The following is a description of a gene set: Extended zone of intimate apposition between two cells containing one or more types of intercellular junctions, e.g., the intercalated disk of muscle. Mouse Gene Set: GOCC_CELL_CELL_CONTACT_ZONE studied in species Mus musculus, and this is the list of marker genes: Cxadr, Slc8a1, Ctnna3, Jam3, Nectin3, Nectin2, Cav3, Vamp5, Ankrd23, Slc9a1, Actn1, Rap2b (RAP2B, member of RAS oncogene family), Pecam1, Pcdh9, Gm1123, Tln2 (talin 2), Cdh2, Pik3ca, Gja5, Ptk2, Dsp, Kcnj11, Pcdha9, Scn5a, Slc31a1, Nrap, Atp1a2, Vcl, Scn1b, Tiam1, Baiap2l2, Prkca, Tjp2, Ank2, Sptan1, Slc2a1, Dsc2, Pkp2, Des, Anxa6, Rangrf, Fxyd1 (FXYD domain-containing ion transport regulator 1), Kcnj2, Sptbn4, Atp1b1, Bloc1s6, Kcna5, Gja1, Scn2a, Afdn, Ywhah, Fgfrl1, Ctnnb1 (catenin beta 1), Gja6, Ajap1, Hamp, Scn1a (sodium channel, voltage-gated, type I, alpha), Slc4a1, Adra1b, Flcn, Ank3, Pgm5, Ahnak, Anxa5, Dsg2, Jup, Ctnna1, Flot1, Itgb1, Atp2a2, Scrib (NCBI Gene Id 54559), Pkp4, Rap2c, Xirp1, Tjp1, Dst, Opalin, Fgf13, Fhod1, Myh1, Obscn, Flot2, Atp1a1, Tmem65, Nectin1, Hamp2, Scn4b, Camk2d, Jam2, Cadm4, Akap6, Pak1